The following is a description of a gene set: Human Gene Set: LANDIS_ERBB2_BREAST_TUMORS_324_DN Down-regulated genes from the genes identified by two analytical methods as changed in the mammary tumors induced by transgenic expression of ERBB2. Upregulation of HER2/ErbB2/Neu occurs in 15-30% of human breast cancers and correlates with poor prognosis. Identification of ErbB2/Neu transcriptional targets should facilitate development of novel therapeutic approaches. Development of breast cancer is a multistep process; thus, to identify the transcriptomes associated with different stages of progression of tumorigenesis, we compared expression profiles of mammary tumors and preneoplastic mammary tissue from MMTV-Neu transgenic mice to expression profiles of wild-type mammary glands using Affymetrix microarrays. We identified 324 candidate genes that were unique to ErbB2/Neu-induced tumors relative to normal mammary gland tissue from wild-type controls. Expression of a subset of these genes (82) was also changed in the preneoplastic mammary glands compared to wild-type controls, indicating that they may play a pivotal role during early events of ErbB2/Neu-initiated mammary tumorigenesis. Further analysis of the microarray data revealed that expression of several known transforming growth factor (TGF)-beta target genes was altered, suggesting that the TGF-beta signaling cascade is downregulated in ErbB2/Neu-induced tumors. Western blot analysis for TGF-beta-Receptor-I/ALK5 and immunohistochemistry for TGF-beta-Receptor-I/ALK5 and phosphorylated/activated Smad2 confirmed that the Smad-dependent TGF-beta signaling cascade was inactive in these tumors. Although absent in most of the tumor, phosphorylated Smad2 was present in the periphery of tumors. Interestingly, presence of phosphorylated/activated Smad2 correlated with expression of Activin-Receptor-IB/ALK4, suggesting that although Smad-dependent TGF-beta signaling is absent in ErbB2/Neu-induced tumors, Activin signaling may be active at the leading edge of these tumors. Cumulatively, these data indicate that the TGF-beta pathway is intrinsically suppressed in ErbB2/Neu tumors via a mechanism involving loss of TGF-beta-Receptor-I/ALK5. from publication Landis MD, Seachrist DD, Montañez-Wiscovich ME, Danielpour D, Keri RA (PMID 15897883) studied in species Mus musculus, and this is the list of marker genes: MKNK2, NDUFV1 (NADH:ubiquinone oxidoreductase core subunit V1), ACAA2, DPEP1, LPIN1, SULT1A1, CD151, CYP4B1, DHRS7, SNRK, TGFBI, SORBS1, HADHB, APLP2, MMUT, COL3A1, KRT19, RRAGC, HLA-DQA2, PAPSS2, CPT2, RAB34, MOCS2, SLC27A1, PTPRB, PGM1, GJB2, AHNAK, HSPB8, ALDH1A1, EPHX2, NDUFAB1, MCCC1, DGAT1, IGFBP6, ADRB3, HEPH, CYB5A (NCBI Gene Id 1528), CFP, CCL11, PDE8A, BCKDHB, DPT, CRIP1, CDC34, FCGBP, ZNF703, CAVIN3, POSTN, NKIRAS1, NET1, COL1A1, DECR1, HADH, NDUFS5, GBE1, CYB5B, GJA1, CHCHD10, TSC22D1, FSTL1, ADIG, CCDC80, FADS1, COL5A1 (collagen type V alpha 1 chain), NR1H3 (NCBI Gene Id 113429), GSTZ1, KLF4, ATP1B3, SPTBN1, PTGES, SEC23A, YWHAG, ANGPTL2, SCP2, CES1, PHYH, RSPO1, UCK1, MRC1, MMP3, GYG1, TMEM205, EIF4EBP1, QKI, ST3GAL6, MAN1A1, CLEC3B, ALAS1, ABHD5, BCAT2, CAVIN2, IDH2, PHLDB1, MFNG, FEZ2, IDH1, LUM, PDHA1, CD34, HTRA1, AUH, UGT1A10, GPD2, UQCR10, COL18A1, CHPT1, MARCKS, FZD4, PPP2R5A, S100A6, JCHAIN, DERL1, PLPP1, GNAI1, PENK, SOWAHC, IVD, CD36, GPAM, MYL9, ACTA2, LAMB1 (NCBI Gene Id 3912), THBD, ALAD, SQOR, TMEM43, GHR, FAM107B, NRP1, GDPD3, BNIP2, MAP4, H6PD, LYL1, DNAJC8, COL4A1, CIDEC, VWF, ADIPOR2, ZEB1, NPC2 (NPC intracellular cholesterol transporter 2), CXCL12, COL6A3, ETFB, SRPX (NCBI Gene Id 8406), ACSL1, GAS6, PLAC8, GPX3, ACAA1